The following is a description of a gene set: from publication Cromer A, Carles A, Millon R, Ganguli G, Chalmel F, Lemaire F, Young J, Dembélé D, Thibault C, Muller D, Poch O, Abecassis J, Wasylyk B (PMID 14676830) Head and neck squamous cell carcinoma (HNSCC) is the sixth most common cancer among men in the developed world. There is a need, for both clinical and scientific reasons, to find markers to identify patients with aggressive disease as early as possible, and to understand the events leading to malignant transformation and susceptibility to metastasis. We report the first large-scale gene expression analysis of a unique HNSCC location, the hypopharynx. Four normal and 34 tumour samples were analysed with 12 600 gene microarrays. Clusters of differentially expressed genes were identified in the chromosomal regions 3q27.3, 17q21.2-q21.31, 7q11.22-q22.1 and 11q13.1-q13.3, which, interestingly, have already been identified by comparative genomic hybridization (CGH) as major regions of gene amplification. We showed that six overexpressed genes (EIF4G1, DVL3, EPHB4, MCM7, BRMS1 and SART1) located in these regions are indeed amplified. We report genes that are highly differentially expressed between 'early' tumours and normal samples. Of these, we validated by quantitative PCR six novel poorly characterized genes. These genes are potential new markers of HNSCC. Comparing patients with relatively nonaggressive and aggressive tumours (without or with clinical evidence of metastasis 3 years after surgery), we identified 164 differentially expressed genes potentially involved in the acquisition of metastatic potential. This study contributes to the understanding of HNSCC, staging patients into prognostic groups and identifying high-risk patients who may benefit from more aggressive treatment. studied in species Homo sapiens Metastatic propensity markers of head and neck squamous cell carcinoma (HNSCC): down-regulated in metastatic vs non-metastatic tumors. Human Gene Set: CROMER_METASTASIS_DN, and this is the list of marker genes: AFG3L2, LAD1, NOP2, DTX2, PPP4C, VSNL1, BAIAP2, SMTN, DUSP7, FXYD3, COL17A1, SLC20A2, ALDOA (NCBI Gene Id 226), TNNT3, MALL, PKP1, MBD2, TPBG, CAV2, CAV1, TOP6BL, UBE2M, TRIM29, FLNB, SDC4, IGSF3, PSMD8 (NCBI Gene Id 5714), SH3GL1, TUBA4A, CELSR1, VDAC3, PHLDA2, ADIRF, PRSS3, SERPINB5, MAST4, TICAM1 (TIR domain containing adaptor molecule 1), KLF5, LMNA, KLK10, JUP, TTLL12, IMPA2, DDB2, GJB3, NCK1, TMEM183A, EIF3K, ATP5F1A, MRPS12, TP63, GSTP1, ALDH4A1, EPAS1, SVIL (NCBI Gene Id 6840), CUL1, ACTA1, CKB, PRODH, PFKP, ATP5F1D, S100A11, BMP1, UBE3C, RAB31, TRIM16, ST6GALNAC2, CEBPZ, TNFRSF10B, PA2G4, MINK1, ITGB4, HSPA2, PLEC, ITGA3, FLAD1, NOP16